The following is a description of a gene set: Catalysis of an oxidation-reduction (redox) reaction in which one substrate is a sterol derivative. studied in species Homo sapiens Human Gene Set: GOMF_STEROID_DEHYDROGENASE_ACTIVITY, and this is the list of marker genes: RDH8, RDH5, AKR1D1 (aldo-keto reductase family 1 member D1), SRD5A2, HSD3B2, DHRS11, RDH14, HSD17B14, HSD17B12, AKR1C2, HSDL1, HSDL2, AKR1B15, HSD17B3, HSD17B13, HSD11B2, SRD5A1 (steroid 5 alpha-reductase 1), HSD3B1, AKR1C4, HSD17B1, NSDHL, DHRS4, HSD17B11, HSD17B8, HSD17B10, AKR1C3, CBR3, HSD3B7 (NCBI Gene Id 80270), HSD17B2, HSD11B1, HSD17B4, HSD17B6, DHRS1, HSD17B7, RDH16, AKR1C1, DHRS9, SRD5A3